The following is a description of a gene set: species: Homo sapiens Human Gene Set: GOBP_REGULATION_OF_PROSTAGLANDIN_SECRETION Any process that modulates the frequency, rate or extent of the regulated release of a prostaglandin from a cell., and this is the list of marker genes: IL1B, PLA2G10, TNFSF11, PTGES, MIF, TNFRSF11A, P2RX7, P2RX4, OXT, EDN1, ACSL4, PLA2G4A, PLA2G3